The following is a description of a gene set: Human Gene Set: GOBP_VIRION_ASSEMBLY A late phase of the viral life cycle during which all the components necessary for the formation of a mature virion collect at a particular site in the cell and the basic structure of the virus particle is formed. studied in species Homo sapiens, and this is the list of marker genes: MVB12B, CHMP1A, APOE (apolipoprotein E), VPS28, RAB1B, VPS37B, MITD1, MVB12A, PC, TBC1D20, NEDD4, CHMP1B, CHMP5, CHMP3, VPS4B, CHMP4A, VPS37C, RAB43, CHMP2A (NCBI Gene Id 27243), CHMP4B, CHMP6, CHMP2B, CHMP4C, VPS37D, DDX6, LRSAM1, TSG101, RAB1A (RAB1A, member RAS oncogene family), SPCS1, USP6NL, VPS4A, CHMP7, CHMP4BP1, VPS37A, PDCD6IP